The following is a description of a gene set: Reactome Pathway: Homologous DNA Pairing and Strand Exchange species: Homo sapiens The presynaptic phase of homologous DNA pairing and strand exchange begins with the displacement of RPA from 3'-ssDNA overhangs created by extensive resection of DNA double-strand break (DSB) ends. RPA is displaced by the joint action of RAD51 and BRCA2. BRCA2 nucleates RAD51 on 3'-ssDNA overhangs, leading to formation of invasive RAD51 nucleofilaments which are stabilized by the BCDX2 complex (RAD51B:RAD51C:RAD51D:XRCC2). Stable synaptic pairing between recombining DNA molecules involves the invasion of the homologous sister chromatid duplex DNA by the RAD51 nucleofilament and base-pairing between the invading ssDNA and the complementary sister chromatid DNA strand, while the non-complementary strand of the sister chromatid DNA duplex is displaced. This results in the formation of a D-loop structure. PALB2 and RAD51AP1 synergistically stimulate RAD51 recombinase activity and D-loop formation. PALB2 simultaneously interacts with RAD51, BRCA2 and RAD51AP1. PALB2 also interacts with BRCA1, and this interaction fine-tunes the localization of BRCA2 and RAD51 at DNA DSBs. The CX3 complex, composed of RAD51C and XRCC3, binds D-loop structures through interaction with PALB2 and may be involved in the resolution of Holliday junctions.<p>While RAD52 promotes formation of invasive RAD51 nucleofilaments in yeast, human BRCA2 performs this function, while human RAD52 regulates single strand annealing (SSA). part of: HDR through Homologous Recombination (HRR), and this is the list of marker genes: TOPBP1, RFC5, CHEK1, BRCA2, BLM, RFC4, RAD51C, NBN, SEM1, WRN, RPA2, RPA3, XRCC3, RAD51, RFC3 (NCBI Gene Id 5983), RAD17, TOP3A (NCBI Gene Id 7156), XRCC2, DNA2, RAD51D, EXO1, BRCA1, RFC2, HUS1, BARD1, KAT5, RHNO1, RPA1, BRIP1, MRE11, RAD51B, RAD50 (RAD50 double strand break repair protein), ATR, RBBP8, RAD9A, RAD9B, RAD1, ATM, PALB2, ATRIP, RAD51AP1, RMI2, RMI1